The following is a description of a gene set: Human Gene Set: GSE1740_MCSF_VS_MCSF_AND_IFNG_DAY2_DERIVED_MACROPHAGE_UP from publication Tassiulas I, Hu X, Ho H, Kashyap Y, Paik P, Hu Y, Lowell CA, Ivashkiv LB (PMID 15467722) Type I IFN-inducible gene expression in human blood monocytes primed with Type II IFN. Genes up-regulated in monocyte-derived macrophages: no priming versus primed by IFNG. species: Homo sapiens, and this is the list of marker genes: LINC00205, ARHGDIA, LRRC4C, POLA2, MINAR1, ST7-AS1, FBXO6, PSMB9, NAA11, HLA-DRB6, ZBTB43, RGMB, CD99L2, KRTAP4-12, NAPEPLD, SMARCD1, MAGEB2, APOF, KLLN, OR2M4, DYNC1H1, CDH3, OR2C3, ELF4, RNF149, GLDC, STX19, NMUR2, GREM2, EGFR, SLC35G1, ZBTB7C-AS2, KIR2DS3, SIPA1L1, HLA-DPB1, CFAP418, MUC19, HLA-DRA, TRAFD1, DESI1, GTF2A1L, MDGA1, PDE10A, ARHGEF28, THUMPD2, PSME2, FGFR2, OR5V1, OR8D2, RNF24, PLD5, CHST3, NLRC5, IGF2BP3, ENSG00000230725, LINC00870 (long intergenic non-protein coding RNA 870), RXRG, IL12RB1, SECTM1, CALCOCO2, FAM83D, PARP14, SP140L, MMP25, APOL6, FNDC5, HLA-DRB1, HCAR3, PATL2, TOX3, TAP1, MRGPRX1, LUZP2, FUT1, CCDC137, EVA1A, RIMS1, NLRC3, GBP1, PERP (p53 apoptosis effector related to PMP22), ANKRD13C-DT, AK8, UGT8, GBP5, ZNF239, POLB, NPHS2, B2M, VWDE, IRF1, SV2C, STAT1, PLS1, GSDMD, CAMK1G, ATG9B, BNC1, TMEM229B, CD3E (NCBI Gene Id 916), HELLS, CALR3, OPN5, ENAH, HINT1, CREM, UBE2L6, BTN3A2, ST6GALNAC1, TEX26, TAP2 (transporter 2, ATP binding cassette subfamily B member), CDK2AP2, PCDH17, PSMF1, HLA-DMB, LRATD1, GBP2, PSMB8, FABP6, PLEKHO1, VN1R3, NXPH1, PSMB10, UPB1, MACROH2A2, RAB30, STOML3, TECRL, GARS1-DT, HLA-DQB1 (NCBI Gene Id 7924), GANC (NCBI Gene Id 2595), HFM1, ZNF280A, TMEM207, TNF, SLPI, GBP4, CZIB, ARHGEF26-AS1, MAPT-AS1, HHLA2, TRPM1, LINC00842, TEX36, MOV10L1, ZNF276, DNPEP, STAT2, TRIM69, WDR76 (NCBI Gene Id 79968), GIMAP8, IQCH, INTU, TRIB2, SPAG11A, LINC00320, NEK2-DT, ACO2, SYPL2, ZNF836, KCNK6, ASB14, CDKL1, GPX2, PTGDR, TRIM21, APOBEC3D, TUBA4B, TDRD1, RSAD2, APCDD1L-DT, SNCAIP, ST7, ZNFX1, TLL1, MR1, FHL2, MAPK11, CXorf58, LAMA3, SCO2, HLA-DOB, MVD, CALHM6, PSMA3, BTN3A1, STYK1, BAK1, SIGLEC6, PLAAT4, LINC01120, TRIM26, ERAP2, KLHL10, WARS1, APOL1, LINC02223